The following is a description of a gene set: species: Homo sapiens Human Gene Set: REACTOME_INSULIN_RECEPTOR_SIGNALLING_CASCADE Insulin receptor signalling cascade, and this is the list of marker genes: THEM4, SOS1, PIK3C3, FGF19, PTPN11, FLT3, FGF1 (NCBI Gene Id 29961), FGF7, PIK3CA, FGF2, KLB, FGF5, FGF8, FGF16, GRB10, MAPK3, PIK3R4, FGF3, INSR, FLT3LG, INS, IRS1, NRAS, AKT2, TLR9, FGF17, FGF9, FGFR3, FGF6, FGF20, FGF18, HRAS, FGF22, PDPK1, FGFR4, FGFR2, GAB2, PDE3B, IRS2, KRAS, FGF10, TRIB3, KL, PIK3R1, PIK3R2, SHC1, FRS2, FGF23, FGF4, FGFR1, GAB1 (NCBI Gene Id 2549), MAPK1, GRB2, PIK3CB